Given this list of marker genes GBP4, FABP3 (fatty acid binding protein 3), ARF4, CYP1B1, UBOX5, ST3GAL1, TMEM183A, FBXO33, TPBG (trophoblast glycoprotein), CHIC2, TGFBI, STXBP3, PPT2, WASHC3, POMC, NUMBL, GSTM1, GID4, RNF5, SLC23A3, UTP11, MAFG, BST2, NDP, BCL2L14, SCHIP1, HDAC6, PCDHB12, CPD, ERCC3, AGFG1, BECN1, GBE1, RHBDD3, NUPR1, IL9R, MKKS, NEDD8, KIAA1143, KLRD1, LTC4S (NCBI Gene Id 4056), METTL3, CPEB1, GDI1, RNF149, PTGDR2, PARD3B, NR0B2, CCL5, ZFAND2A, CHD6, SLFN13, TMCO3, HTATIP2, POLR2C, HSPA1A, RAB10, PIK3CG, P4HA2, GRINA, TRMT112, TPGS1, CREBZF, ZNF605, IRGM, CD81, COG6, H2AC25, G3BP2 (G3BP stress granule assembly factor 2), USO1, TNRC6A, MORN3, NIPAL2, SRRM1, PHYHD1, ZNF189, MOCS2, PARD6A, SEMA3C, TAGLN2, MX2, TLE2, PDIA5, KDR, MITD1, GSPT1, CPA5, UBR1, POLR1C, CNMD, CRIPTO (cripto, EGF-CFC family member), ANXA5, C5orf15, GRB2, MARCO, RAB23, APPBP2, TMEM39A, LYSMD3, ABI1, CDKN2D, PPP1R2P1, CD47, TMA16, MTF1, USP15, PTGR3, OSGIN1, ETNK1, ZNF821, CRELD1, SLFN12L, EVC, SYNJ2BP, KCNE1, MDFIC, ASNS, HAX1, NKIRAS1, CYBB, NAB1, ATF5 (activating transcription factor 5), BCKDHB, SLAMF6, DLL4, PSENEN, ITGA4, NIT1, SNX15, ATOSB, TPD52L2, PEX19, OTUD7B, SOWAHC, COL5A1, PMVK, RDH13, AP1G1, SYPL2, OSTF1, XCR1, APBB2, TMEM38B, TRAT1, VPS16, DDIT3, UBXN10, GJB3, ADRB3, PC, POLR1E, NDUFA7, TMED7, TMEM33, CAMTA2, TULP1, IMP3, GTPBP2, SLC28A2, GYPC, CYP4F3, VAMP8, IREB2, ZFAND3, IRF8, CCDC71, EPHA1, SLC39A4, LRRC41, DLK1 (delta like non-canonical Notch ligand 1), WDR6, ENKD1, SNX10, KLHL24, RAB33B, UBXN8, PMPCA, PTGR1, SRI, COL4A4, TSPAN33, EMC7, HP1BP3, MGST2, UBE2L6, CYBC1, PPP1CB, ATG12, TAP1, VEGFC, NOXO1, PNKD, SMPD4, HMG20A, CHRAC1, ADAMTS7, SLC17A2, PGM1, MFSD6, here is a description of the gene set: mouse primary BMDCs were stimulated with tlr ligands and gene expression changes were profiled on Affymetrix arrays studied in species Homo sapiens Human Gene Set: GSE17721_0.5H_VS_24H_LPS_BMDC_DN Genes down-regulated in comparison of dendritic cells (DC) stimulated with LPS (TLR4 agonist) at 0.5 h versus those stimulated at 24 h. from publication Amit I, Garber M, Chevrier N, Leite AP, Donner Y, Eisenhaure T, Guttman M, Grenier JK, Li W, Zuk O, Schubert LA, Birditt B, Shay T, Goren A, Zhang X, Smith Z, Deering R, McDonald RC, Cabili M, Bernstein BE, Rinn JL, Meissner A, Root DE, Hacohen N, Regev A (PMID 19729616)